Given this list of marker genes Dlg1, Dlg4, Gria4, Ptprd, Grin2a, Ptprf, Lrfn4, Grin2d, Flot1, Grin1, Lrfn3, Flot2 (NCBI Gene Id 14252), Rtn3, Grin2c, Lrfn1, Gria1, Lrfn2, Dlg3, Gria3, Ptprs, here is a description of the gene set: species: Mus musculus Synaptic adhesion-like molecules Mouse Gene Set: REACTOME_SYNAPTIC_ADHESION_LIKE_MOLECULES